Given this list of marker genes SAV1, SMAD1 (NCBI Gene Id 4086), NDRG4, NKX2-5, MYH10, RBPJ, MIR19B1, FOXC1, PIM1, FGF9, MIR548C, FES, MAPK11, NRG1, ARID2, ERBB4, MIR509-1, MIR204, ABL1, NOTCH1, HEY2, RUNX1, TGFBR3, RXRB, FGF2, TGFB2, MEF2C, MIR199A1, MIR1-1, YAP1, VGLL4, BMPR1A, ZFPM2, SKI (SKI proto-oncogene), RBP4, GLI1, FGFR2, CDK1, MIR199B, GATA6, TBX5, KRAS, TP73, DIPK2A (NCBI Gene Id 205428), FOXC2, CCNB1, MIR222, MIR200B, MAPK14, FGF20, TGFBR1, JARID2, TENM4 (teneurin transmembrane protein 4), MIR590, TBX2, MIR17HG, TBX20, WNT2, PRKAR1A, BMP10, NOG, FGFR1, MIR873, KCNK2, here is a description of the gene set: species: Homo sapiens Human Gene Set: GOBP_CARDIAC_MUSCLE_CELL_PROLIFERATION The expansion of a cardiac muscle cell population by cell division.